The following is a description of a gene set: Progeria-associated lipodystrophy Human Gene Set: WP_PROGERIAASSOCIATED_LIPODYSTROPHY studied in species Homo sapiens, and this is the list of marker genes: LMNB1, FNTA, SMAD2, MUCL3 (NCBI Gene Id 53370), SPRTN, ZMPSTE24, KCNJ6, TGFB1, FFAR3, LMNB2, PARP1, POLD1, ICMT, SMAD3, PPARG, LMNA, INS, FBN1, RECQL, BANF1, WRN, SMAD4